Given this list of marker genes FPR2, CD300LD, PITPNM2, TNNT3, FTMT, RAB11FIP1, ATAD5, NRP1, CDH4, CNPY4, PANX1, MFSD4A, TAF13, EDNRA, GSTO2, AR, RPL3, PRUNE1, TIPIN, RNF149, IL6ST, SCD, CCL4, PTK2, MGST1, IDUA, MRNIP (MRN complex interacting protein), RIF1, IWS1, ISOC1, UNG, ADAP2 (ArfGAP with dual PH domains 2), PSTPIP2, TUBB2A, MAOA, MC3R, IFNGR1, STK35, EXT1, MCM7, G3BP1, ENPP2, GCC2, LYZL4, SMARCA5, PNPT1, CBLC, PLEKHN1, PTPN2, ARX, CHD9, GORAB, GFRA3, ZNF263, SLC30A2, IL25, GSR, UROS, RABL3, ACP7, NR1H3, C11orf96, RB1, HAND1, GPR19, YTHDC1, THOC7 (NCBI Gene Id 80145), BMP15, TEX13B, TBC1D23, OAS3, ZBP1, SLC4A7, JUNB, IFNG, DUSP4, CCDC122, BEX4, DNAJC8, HOXD13, ECHDC2, MAP3K8 (NCBI Gene Id 8040), MKI67, PGD, PLK2, CEBPB, CTNNAL1, MAFK, LDLRAD3, RSPO2, HIP1, EFHD2, SLFN12, POLE, NFIX, CALCRL, PRSS37, ZC3H12A, U2SURP, LEFTY2, PKN3, MTPN, WDR18, CYRIA, KCNK3, PIWIL2, CYP2W1, NRDE2, RWDD3, ZFP36L1, DNAAF4, SOD2, MED13L, UQCRB, ADRA2B, RNASE2, HOXD12, SRSF5, SNED1, KLF4, LPL, ATP6V1C2, LDLR, TRIM13, VCAM1, MTHFD1, MAT2A (methionine adenosyltransferase 2A), CYSLTR1, C11orf97, NRROS, BTG2, AK1, PDK1, HMGN3, JARID2, ENSG00000285566, PPP3CB, SRSF6, EPC1, LAIR1, MRPL52 (NCBI Gene Id 122704), PPP1CB, PLPP3, NIBAN1, RIGI, HNRNPUL1, RND3, DMAC2L, RAC1, GJA1, PHF19, LAMC2, CPPED1, MPST, TOR1AIP1, SGK3, ENOX2, VSIG10L, NSUN5, INSIG1, EHD1, TXNRD1 (thioredoxin reductase 1), BACE1, SRR, C19orf48P, IFI44L, C11orf65, ZCCHC24, TUBB2B (tubulin beta 2B class IIb), SLC39A5, NR4A2, IRF9, ZMAT2, CLCN1, CEP70, SOX13, KCTD16, DUSP10, CGAS, GLRX, ARID5A, ELL, NKAPD1, PIK3R3, CALR3, IBTK, EGR4, TUBB, STAT1, GRIN1, SIK2, PARP12, NEDD9, GBP7, ETV3, AHR, SNCB, SLC25A24, CAND1, MIR22HG, here is a description of the gene set: studied in species Homo sapiens IRAK-4 is an essential component of the signal transduction complex downstream of the IL-1- and Toll-like receptors. Though regarded as the first kinase in the signaling cascade, the role of IRAK-4 kinase activity versus its scaffold function is still controversial. In order to investigate the role of IRAK-4 kinase function in vivo, ‘knock-in’ mice were generated by replacing the wild type IRAK-4 gene with a mutant gene encoding kinase deficient IRAK-4 protein (IRAK-4 KD). Analysis of bone marrow macrophages obtained from WT and IRAK-4 KD mice with a number of experimental techniques demonstrated that the IRAK-4 KD cells greatly lack responsiveness to stimulation with the Toll-like receptor 4 (TLR4) agonist LPS. One of the techniques used, microarray analysis, identified IRAK-4 kinase-dependent LPS response genes and revealed that the induction of LPS-responsive mRNAs was largely ablated in IRAK-4 KD cells. In summary, our results suggest that IRAK-4 kinase activity plays a critical role in TLR4-mediated induction of inflammatory responses. Genes down-regulated in comparison of untreated macrophages from IRAK4 deficient mice at 4 h versus those treated with LPS (TLR4 agonist) at 1 h. Human Gene Set: GSE9037_CTRL_VS_LPS_1H_STIM_IRAK4_KO_BMDM_DN from publication Koziczak-Holbro M, Glück A, Tschopp C, Mathison JC, Gram H (PMID 18266302)